The following is a description of a gene set: Any process in which a protein is transported to, or maintained at, a region of a chromosome at which a DNA double-strand break has occurred. species: Mus musculus Mouse Gene Set: GOBP_PROTEIN_LOCALIZATION_TO_SITE_OF_DOUBLE_STRAND_BREAK, and this is the list of marker genes: Iffo1, Trp53bp1, Rad17, Slf2, Rpa1, Cyren, Mdc1 (mediator of DNA damage checkpoint 1), Parp3, Brme1, Slf1, H2ax, Xrcc4, Htatsf1, Rhno1, Nbn, Sirt6, Topbp1